The following is a description of a gene set: species: Homo sapiens from publication Travaglini KJ, Nabhan AN, Penland L, Sinha R, Gillich A, Sit RV, Chang S, Conley SD, Mori Y, Seita J, Berry GJ, Shrager JB, Metzger RJ, Kuo CS, Neff N, Weissman IL, Quake SR, Krasnow MA (PMID 33208946) Human Gene Set: TRAVAGLINI_LUNG_PROLIFERATING_MACROPHAGE_CELL, and this is the list of marker genes: ATP2C1, IFI27L1, GPX1 (NCBI Gene Id 2876), FABP4, OAZ1, ISOC2, NDUFB6, SEPTIN11, CENPK, BLOC1S1, CCL23, LAP3, SCCPDH, MCM5, C8B, TREM1 (triggering receptor expressed on myeloid cells 1), PIMREG, SPG21, MYDGF, LSM3, GGH, PSAP, ANAPC11, LSM4, GMPS, MT1F, KIF5B, TAGLN2, ALDH2, TMBIM4, HCFC1R1, LAMTOR1, NTAN1, GSDMD, SUMO3, BIRC5, TXNDC17, MKI67, PPIC, DBI, RPN2, MESD, ACAT1, ACTN1, PSMD8, BCL2L12 (NCBI Gene Id 92647), AGRP (NCBI Gene Id 181), CCL20, ILVBL, CD52, SHCBP1, SIRPB1, RPA3, WASHC3, RRM1, GPCPD1, UBASH3B, HEXA, CENPS, PSMB6, HNRNPAB, MAD2L1, MCUR1, UBE2S, AK6, HMG20B, REEP4 (NCBI Gene Id 80780), IFI30, ANP32E, IER3IP1, PLP2, ATP6AP1, AP2S1, MCM7, SLC25A5, TMPO, STX12, PARP9, PSMA4, FABP5, ANXA4, ZDHHC12-DT, GPX4, STMN1, ZWINT, C2, ECHDC1, BLOC1S2, ABCG2, CXCL2, DYNC2I2, C1QB, GYPC, MRPL14, TSPO, C1orf162, PSMC1, ABCG1, RAD51AP1, LSM5, EMC9, TYROBP, SPPL2A, TMSB4X, FAM3B, ABHD12, TMED5, FDX1, CAPZA2, CCT5, SLC2A6, ANPEP, PSMD7, EZH2, SMS, ANXA2, CEP15, ESCO2, IFIT3, AKR1C3, TRIP6, PTGR1, COLEC12, STAC3, PNPLA6, AKR7A2, NDUFV2, ANXA1, NAPRT, CENPA, PSMB3, PRDX5, ACOT7, RANBP1, HNMT, PCBD1, RFC4, NUCKS1, RAN, HMGB2, E2F1, MRPL18, PSMC2, ADTRP, FH, DEK, BUB1, HSP90AA1, PELATON, COPRS, GRINA, MYL12B, HLA-DQB1, LPL, SCARB2, BARD1, HTATIP2, CCNB2, EIF4EBP1, H2AX, PPA2, UHRF1, CBR3, PRR11, CENPN (centromere protein N), ORMDL2, RACGAP1, TK1, S100A4, TIMM10, RTN4, ARPC3, LAMTOR2 (NCBI Gene Id 94954), CBR1, ATP6V1H, ATOX1, FUCA1, PARAL1, UNC93B1 (NCBI Gene Id 81622), CTSZ (NCBI Gene Id 1522), ZBTB8OS, PPM1G, MCOLN1, MS4A6A, H1-4 (H1.4 linker histone, cluster member), GET3, CALM2, PRC1, KCNA3, PFKL, PSMG2, MSR1, CTSS, S100A13, ASAH1, QSOX1, CNIH4, ADISSP, PSMA6, EIF4A3, PHLDA3, KYNU, ARHGAP11A, CIAO2A, BATF3, HYI, LAIR1, FCER1G, SORT1, ARRDC4, LIPA, NMB, MRPL37, MGMT, MTMR11, AVPI1, ALOX5AP, BRCA1, ACO1 (NCBI Gene Id 48), ABHD5, PSMD14, IFI6, ENOSF1, DTYMK, ACADVL, ATP1B3, IGFBP2, GCHFR, PGP, TUBA1B, CST3 (NCBI Gene Id 1471), IL1B, POLD1, FAM50A, PNP, CIP2A, ARHGAP18, NCF2, NDC80, BCAP31, USP1, TALDO1, VSIG4, AQP3, UBE2E2, CYB5R3, CDKN2C, CRIP1, ANG, SSR3, NUPR1, HADH, DNAJC9, TGM2, DNAJC15, UBE2L3, TMED3, RHEB, H2AZ1, TUBB, DDX39A, VAMP8, HCK, AKR1B1, ZDHHC12, HADHA, LSM2, DENND5A, CAPG, AKR1C2, SLC25A24, PSMB2, ASRGL1, CTSH, SDCBP, ATP6V0E1, SNRPD1, GLIPR2, MMP19, LRPAP1, TCEAL8, MGST2, ENO1, DPYSL2, CLIC4, CTSA, FTH1, HIRIP3, SNX2, ACOT13, EMC3, PTTG1, PSMA3, CREG1, HSPE1, SOD1, GTF2A2, TROAP, LDHB, ANLN, EDEM2, HINT2, ATG3, ANP32B, GINS2, HSD17B11, CTNNA1 (catenin alpha 1), HAUS4, RAB32, CCDC34 (coiled-coil domain containing 34), HSPB1, APOE, ASPM, CCNB1, CDCA5 (NCBI Gene Id 256676), LY96, ARPC2, RPS27L, MARCO, AAMDC, TACC3, DHFR, TMEM165, SNX3 (NCBI Gene Id 8724), SPARC, MIS18BP1, EIF2S2, TUBG1, POGLUT3, TOP2A (DNA topoisomerase II alpha), PIGT, SVIL, PLXDC2, KIFC1, APIP, MNDA, CDK1, MRPS18C, TPX2, LRRCC1, CARHSP1 (calcium regulated heat stable protein 1), CPE, PSMA5, FDFT1, MRPL57, CLTA, ARL4A, VDAC2, BRCA2, QDPR, CD86, SPNS1, CD163, BHLHE40, NDUFA4, RNASE4, SPI1, CEP55, CSE1L, TPI1, CENPE, COA6, CD68, RTN3, CD164, CXCL5, FBP1, LACTB, PPARG, C1QC, NUCB1, EXOSC9, HAT1, CAVIN3, MPZL2 (myelin protein zero like 2), TXN (NCBI Gene Id 7295), PKMYT1, PHGDH, PRSS21, RAD23A, PTX3, MRPL17, CALM3, HLA-DQA1, BST1, UBE2C, AKIP1, MRPS15, DRAM1, CAT, CXCL10, MS4A4A, FOLR3, LEPROT, CKS1B, HMGN2, SERINC2, TXNDC12, TUBB2A, ATP6V0C, MCM4, CD74 (CD74 molecule), DEFB1, PLD3, CTSB (cathepsin B), FBXO5, CCL18, SLC3A2, ATP6V0D1, YWHAH, TAGLN, PRRG4, AGPAT2, PSME2, CLSPN, APOC1, RPN1, RMDN3, BRI3 (brain protein I3), OSCAR, TMEM219, GMNN, YWHAE, H4C3, ALCAM, GLDN (NCBI Gene Id 342035), PCOLCE2, RRM2, IL18 (interleukin 18), GPX3, CCDC47, STXBP2, YBX1, TPRKB, CAMP, PYCARD, LTA4H, COLGALT1, HLA-DRB1, SNRPB, APOL4, FAM111B, SNRPG, SLBP, POLD3, NDUFS8, CDKN2A, IL17RB, S100A10, S100A11, NUP214, TMED9, TRIOBP, GAPDH, COMT, CD151 (NCBI Gene Id 977), COQ2, H2AC20, CDK4 (NCBI Gene Id 92978), ACYP2, MPC2, ATAD2, GNG5, GTF3C6, PDLIM7, DYNLL1, TSPAN4, NUDT21, PDXK, NUDT5, UFD1, SERPINA1, ETFB, ELOB, BLVRB, CHMP5 (NCBI Gene Id 51612), SMC4, TMEM14C, MRPL51, IDH2, HMGB3, DNAJA1, BHLHE41, CTNNB1, MT1E, RNPEP, SEC11A, PLAUR, HAGH, OSBPL11, CDT1, CXCL3, H2AC17, S100A6, OAS1, HPRT1, MRPL27, CXCL16, MACC1, ILF2, RALBP1, MELK, TCN2, DCTN6 (dynactin subunit 6), MT1L, SLC16A3, MDH1, NUSAP1, SLC25A11, DDB2, PLAAT3, ITM2B, DCK, H1-2, DCTPP1, HSPA1A, H2AJ, BSG, ACVRL1, RAC1, FCGR3A, PCNA, PSMD1, GSN, POC1A, TREM2, RBBP7, FCGR1A, H1-3, PTMS, MCM3, SAE1, MTX1, CCDC18, CDCP1, MGST3, PAPSS1, HMGN3, OASL, HLA-DQA2, CD59, INHBA, C1QA, PAFAH1B3, PLSCR1, FPR1, PEBP1, RAD51, GAS2L1, ZNF706, DLGAP5, DUT, CDCA2, SCD, ATP6V1F, ATP5PF, KPNA2, JPT1, SLC27A3, PSMA7, MRPL34, MS4A7, TGFBI, ALOX5, TSPAN3, RER1, TP53I3, HEXB (NCBI Gene Id 3074), PHF19, GPSM2, SUMO2, PRIM1, NDUFB5, CORO1C, FOXM1, FUOM, LGALS1, PTPN12, REEP5, OLR1, LIG1, LYAR, DIAPH3, B2M, CCNA2, SLC11A1, SLC15A3, CTSD, POLR2K, MSRB2, RND3, TFPT, NCAPH2, SNRPD3, SARNP, REEP3, GPA33, MTCH2, ATP5F1C, MZT1, GPNMB, PLIN3 (NCBI Gene Id 10226), RETN, CENPF, PLIN2, ALDOA, VRK1, ALDH1A1, LAMP1, BTG3, TUBA1C, CCRL2, ARL2, DST, TMBIM6, PECAM1, UQCR10 (NCBI Gene Id 29796), TPGS2, COX8A, ATP6V1E1, HDDC2, TNFAIP6, SPAG5, BLVRA, TCEAL9, HLA-DMA, LY6E, PTPMT1, UBE2L6, IL1RN, ADPGK, AMIGO2 (NCBI Gene Id 347902), CXCL8, LRR1, ATP6V0B, MRPS16, ETHE1, DCTN3, COMMD4, FANCI, NCF4, MCEMP1, GLRX, TMED10, TEDC1, FAM89A, ENY2, SIVA1, KIF14, CSTA, SCP2, RGCC, GNB2, UQCRQ, GGA2, CALM1, TAF9, PSMA2, TMEM107, SEPTIN10, FIBP, CD9, POLR3K, KIF23, CKAP2L, CRNDE, CTSC, COX6C, CHCHD2, PPT1, NENF, MGST1, HSD17B4, NIT2, PIN1, TECR, SGMS2, PRPS2, CLDN7, ECHS1, POR, VAT1, PSMB5, CXCL1, RBX1, RAB13 (NCBI Gene Id 89672), MTHFD2 (methylenetetrahydrofolate dehydrogenase (NADP+ dependent) 2, methenyltetrahydrofolate cyclohydrolase), TCEAL4, NQO2, FCGRT, NDUFAF3, HACD4, CENPU, GAA, LGALS3BP, SNRNP25, PGD, SSB, ERH, MME, SPATS2L, UBE2A, KNL1, CDCA3, RNH1, GLB1, FAM111A (FAM111 trypsin like peptidase A), PHYH, HJURP, OIP5, ITGB8, MT1G, RAB34, HACD3, SCPEP1, HLA-DRB6, OPN3, VMA21, AKR1A1, LYZ, RHBDD2, DAB2, ROGDI, ASF1B, TMEM59, FCGR1BP, TMEM160, MFSD1, ORC6, CDC20, MRC1, SIRPA, MPHOSPH6, TGOLN2, NANS (N-acetylneuraminate synthase), GPN3, GIHCG, CTSL, MZT2B, HMGN1, ATP6AP2, RDX, MCM6, BCAP29, PCMT1, VDAC3, ALAS1, DNMT1, STING1, SDC4, ATL3, CYP27A1 (NCBI Gene Id 1593), H2AZ2, GBP1, HSP90B1, CFL1, MX1, SERPING1, CKAP2, HSBP1, HLA-DPB1, MRPL13, GPD1, TMEM14B, IFT25, TNIP3, KNSTRN, MIR3945HG, UBE2T, VIM, SLC31A1, ALG9, MT2A, SKIC8, RRAGD, UPP1, DYNLRB1, HLA-DRB5, GCA, NASP (NCBI Gene Id 96573), RPL26L1, NAA20, RAD21, HLA-DPA1, CCDC88A, MND1, MPC1, SKA2, STOM, PDLIM1, PCLAF, CFD, YWHAB, ARPC1B, NCEH1, SAC3D1, CES1, KIF2C, TMEM106C, SGO1, PILRA, ITGB3BP, LRP1, FUCA2, HMGB1, PRDX3, GLUL, ATP5MC3, HAUS1, ATP2B1, SGO2, BAX, HERC5, MAGOHB, DEPDC1, BANF1, MTFR2, NOP10, CENPW, RHOA, KIF11, DMAC1, GLA, UROD, RFC2, SH3BGRL, ACAA2, LGALS3, PSMC3, MICOS10, FDPS, NCAPG, VMO1 (NCBI Gene Id 284013), GLO1, AURKB, CD47, ACAT2, NDUFC2, CENPH, SQOR, VPS29, IFI27, FEN1, SLC7A7, ARL6IP1, ACER3, ECSCR, PBK, PKM, CALU, LY86 (lymphocyte antigen 86), FTL, ALDH7A1, FHL1, SNX10, GUSB, UQCC2, TUBB6, FN1, CENPM (NCBI Gene Id 79019), CKS2, TKT, TEX30, ADAMTSL4, MYL6, MPP1, TCEAL3 (NCBI Gene Id 90845), KIF20B, PLK1, CD63, ANXA5, COX5A, SCGB3A1, HSPD1, GPD2, ECH1, SLC31A2, SMIM30, HP, IGSF6, HLA-C, NDUFB3 (NADH:ubiquinone oxidoreductase subunit B3), NUDT1, UQCRC1, SMC2, ARPC5, PFN1, CACYBP, PGK1, EMC7, MT1X, HADHB, ACP5, VKORC1, HAUS2, TOMM5, ZCRB1, BCL2A1, PRDX1, BUB3, SKA3, TIMP2, NUCB2, IL3RA, TCF7L2, SAP18, MACROH2A1, GSTP1, CD14, TCF19, PTTG1IP, DECR1, GRN, CYB5A, AURKA, CISD2, UBB, PLBD1, CDKN3, RBP4, TUBB4B, GTSE1, IL6, LDHA, AXL, RNASEH2A, POMP, EPHX1, DNASE2, MXD3, ELOC, PLEKHB2, CD81, NNMT, ATP6V1D, NDUFA12, NPC2, ALDH3A2, CD58 (NCBI Gene Id 965), TYMS, APLP2, HLA-DRA, KIF22, PPIA, JAML, MDK, CSTB, SRD5A3, NELFE, SERF2 (small EDRK-rich factor 2), PRDX4, LGALS9, ERP29, GSTO1 (glutathione S-transferase omega 1), ERP44, SPC25, HDAC2, SMCO4, OSBPL1A, ATP1B1, CPVL, LAMP2, HMMR, ACOT4, CYBA, GNAS, NUF2, MYBL2